The following is a description of a gene set: species: Rattus norvegicus Genes down-regulated in GH3 cells (pituitary cancer) after treatment with LIF. Human Gene Set: ABBUD_LIF_SIGNALING_2_DN Leukemia inhibitory factor (LIF) mediates the hypothalamo-pituitary-adrenal stress response. Transgenic mice overexpressing LIF in the developing pituitary have altered pituitary differentiation with expansion of corticotropes, maintenance of Rathke's cleft cysts, and suppression of all other pituitary cell types. Affymetrix GeneChips were used to identify modulators of LIF effects in corticotrope (AtT-20) and somatolactotrope (GH(3)) cells. In addition to genes known to respond to LIF in corticotrope cells, corticotrope-specific changes were also observed for genes involved in glycolysis and gluconeogenesis, transcription factors, signaling molecules, and expressed sequence tags. Two transcription factors identified, CCAAT/enhancer-binding protein beta (C/EBPbeta) and glial cell-derived neurotrophic factor (GDNF)-inducible factor (GIF), dose-dependently induced expression of the rat POMC promoter when overexpressed in AtT-20 cells. LIF further induced POMC transcription with C/EBPbeta, but not with GIF. C/EBPbeta also induced expression of the SOCS-3 promoter that was further enhanced by cotreatment with LIF. However, GIF did not affect SOCS-3 expression. These results indicate that C/EBPbeta and GIF are downstream effectors of LIF corticotrope action. LIF also stimulates the expression of inhibitors of its actions, such as SOCS-3 and SH2 domain-containing tyrosine phosphatase-1. alpha(2)-HS-glycoprotein (AHSG)/fetuin, a secreted protein that antagonizes bone TGFbeta/bone morphogenic protein signaling, was induced by LIF in a signal transducer and activator of transcription-3-dependent fashion. Pretreatment with AHSG/fetuin blocked LIF-induced expression of the POMC promoter independently of SOCS-3. Thus, using GeneChips, C/EBPbeta and GIF have been identified as novel mediators and AHSG/fetuin as an inhibitor of LIF action in corticotropes. from publication Abbud RA, Kelleher R, Melmed S (PMID 14576184), and this is the list of marker genes: ZNF280D, PTHLH, CITED2, NALCN, SCN1A, PITX2, CGA